Given this list of marker genes MLX, HLA-B, IL12B, HYOU1, UBA1, here is a description of the gene set: Human Gene Set: HP_ARTERITIS Arteritis Arterial inflammation. studied in species Homo sapiens